Given this list of marker genes GLIPR2, SLC1A2, SSR3, CSTF2, ANKRD33B (NCBI Gene Id 651746), TMEM39A, DNAJC13, ATF5, RASSF3, RPL23, PTTG1IP (PTTG1 interacting protein), TMED2, GNS, UBE2R2, AP3S1, MARCKSL1, ALDH1A2, IK, SECISBP2L, DHPS, SNX12, SPOP, ABCG1, HSDL2, SRP9, AREG, RNF157, ANP32E, HPS4, RNF187, RAB4A, CLDN1, EP400, DOCK1, CDH1, CD200 (CD200 molecule), SYNPO, SSBP3, KCTD12, HIBADH, LITAF, PLPPR4, ANXA7, SERPINB9 (serpin family B member 9), SCPEP1, NPC2, MED22, CD44, INPP5B, AMOT, QPCT, TOP1, GSR, MYOM1, COA5, DNAJB2, PMEPA1, CHMP4B, NDRG2, B3GNT5, RCSD1, FSCN1, ACADL, CCNG2, CYP4A22, KRT85, MAP4K4, LDLRAD4, SDC2, LAD1, VWA5A, NOL11, NDRG1, NMT1, EIF2S3, GPATCH4, ARL5A, CDV3, SOCS3, TFCP2L1, ACLY, SPINT2, IDI1, LARS1, SRP19, DENND4C, ABCA1, QDPR, NSMCE3, GPR137B, HEPH, NID1, RAB13, IL2RA, DNAJC3, CTNNBL1, COG6, FKBP1A, ZBTB8A, ADK, ZDHHC14, BASP1, TRAPPC10, DHCR24, BCL2L14, CCL17, PLS3, RBM17, TRIB1, ANXA4, SLC6A1 (NCBI Gene Id 6529), MX2, CREG1, MAGT1, ELL2, THAP12, P2RY14, MID1IP1 (MID1 interacting protein 1), FABP5, SLC52A3, NSMCE2, HTRA1, SLC22A3, CRIP1, PCBP3, GADD45A, ADCY6, NDUFB7, SEC61A1, CLN5, LAPTM4B, CANX, PSMD11, GCA, KCNE2, RGS10, AQP9, CPNE3, DLG3, EMC3, NMT2, SIN3B, SWAP70, ATAD2B, TAS1R3, MPI, ATP2A2, TSTD2, RSPRY1, GNB4, CCL22, TXNDC17, TNFRSF13C, STXBP6, USP7, DNTT (NCBI Gene Id 1791), GTF3C6, GLCE, TBL1X, CSRP1, TAPBPL, TXN, MYLK, RHOC, CALCB, HIVEP1, GPATCH8, STAP2, MORF4L2 (NCBI Gene Id 9643), OR4E2, PTPN21, NUMB, GPR37, LAMP2, NEXMIF, EPSTI1, PAM, LOXL3, YWHAZ, CACNB2, CLU, MYDGF, PLAAT3, MYL6, NHERF2, CLDND1, CACUL1, PSMD2, INSL6, RAB10, TUBB2A, IDO1, HMGCS1, TM4SF5, HMGN3, DNAJC1, STBD1, PAFAH1B2, ELOVL6, TNNT2, here is a description of the gene set: We identified Pparg as a major orchestrator of the phenotype of adipose-tissue resident regulatory T cells (VAT Tregs). To establish the role of Pparg in shaping the VAT Tregs gene profile and cell dynamics, Tregs from lymph nodes and visceral adipose tissue of mice sufficient and deficient of Pparg expression in Tregs were double sorted for microarray analysis. from publication Cipolletta D, Feuerer M, Li A, Kamei N, Lee J, Shoelson SE, Benoist C, Mathis D (PMID 22722857) species: Homo sapiens Human Gene Set: GSE37532_WT_VS_PPARG_KO_VISCERAL_ADIPOSE_TISSUE_TREG_DN Genes down-regulated in T reg from visceral adipose tissue of aged mice: wildtype versus PPARG knockout.